Given this list of marker genes IL13, SPDEF, WNT7B, ADAMTSL2, HOXA5, AGR2, here is a description of the gene set: species: Homo sapiens The biological process whose specific outcome is the progression of a lobar bronchus from an initial condition to its mature state. This process begins with the formation of the lobar bronchus and ends with the mature structure. The lobar bronchus is the major airway within the respiratory tree that starts by division of the principal bronchi on both sides and ends at the point of its own subdivision into tertiary or segmental bronchi. Human Gene Set: GOBP_LOBAR_BRONCHUS_DEVELOPMENT